Given this list of marker genes GABRA3, KCNJ18, CACNA1S, SCN4A (NCBI Gene Id 6329), KCNE3, ATP1A1, here is a description of the gene set: An abnormally decreased potassium concentration in the blood occurring periodically with a return to normal between the episodes. Episodic hypokalemia studied in species Homo sapiens Human Gene Set: HP_EPISODIC_HYPOKALEMIA